Given this list of marker genes WFS1, SRSF6, CAST, PDX1 (pancreatic and duodenal homeobox 1), NEUROD1, TCF7L2, here is a description of the gene set: Any process that stops, prevents or reduces the frequency, rate or extent of type B pancreatic cell apoptotic process. studied in species Homo sapiens Human Gene Set: GOBP_NEGATIVE_REGULATION_OF_TYPE_B_PANCREATIC_CELL_APOPTOTIC_PROCESS